The following is a description of a gene set: A deformity of foot and ankle in which the foot is bent down and outwards. studied in species Homo sapiens Human Gene Set: HP_TALIPES_EQUINOVALGUS Talipes equinovalgus, and this is the list of marker genes: CHST3 (carbohydrate sulfotransferase 3), FLNB, TTI1, ATAD3A, PTRH2, ESCO2, CLTCL1, LMX1B, ABHD16A, B4GALT7, B3GAT3, GDF5, TNNT3, OTUD5